Given this list of marker genes FRAS1, TTC7A (tetratricopeptide repeat domain 7A), WNT4, THSD1, PI4KA, MDFIC, LZTR1, CRLS1, RHD, NUP88, here is a description of the gene set: An anomalous structural finding of the fetal lungs. Terms in this subhierarchy are restricted to findings that can only be observed in the prenatal period. Other HPO terms can also be used to describe fetal phenotypes. species: Homo sapiens Human Gene Set: HP_ABNORMAL_FETAL_PULMONARY_MORPHOLOGY Abnormal fetal pulmonary morphology